The following is a description of a gene set: studied in species Homo sapiens Human Gene Set: GOBP_NEGATIVE_REGULATION_OF_REACTIVE_OXYGEN_SPECIES_BIOSYNTHETIC_PROCESS Any process that stops, prevents or reduces the frequency, rate or extent of reactive oxygen species biosynthetic process., and this is the list of marker genes: RHOA, PARK7, ABCD1, NDUFC2, PRKN, STAT3, CFLAR, ADCY10, MPV17L, PAGE4, MIR590, ABCB7, TRAP1, SLC18A2, MIR181A2, MIR21, INS, ABCD2, FYN, PPARA